Given this list of marker genes AKR1A1, XYLB (xylulokinase), CRYL1, DCXR, TKT, SORD, here is a description of the gene set: species: Homo sapiens Human Gene Set: GOBP_XYLULOSE_5_PHOSPHATE_METABOLIC_PROCESS The chemical reactions and pathways involving xylulose 5-phosphate, a derivative of the ketopentose xylulose phosphorylated at the 5 carbon; it is an intermediate in the pentose phosphate pathway.